Given this list of marker genes EPHA3, ANGPT4, TRIM60, CHKB, RBM24, MPPED2, SELENBP1, SUN3, CHL1, PARVA, CAMKK2, ZDHHC11, TAF10 (NCBI Gene Id 6881), SMYD2, AZIN2, CRYGD, NAV1, SFRP4, TUBA4A, CYP2S1, ROMO1, TPI1, GDF2, MYO1H, DPYSL5, EBPL, MATCAP1, NXF2, TSPYL5, SMYD1, ZNF385A (NCBI Gene Id 25946, zinc finger protein 385A), VPS28, YIF1A (Yip1 interacting factor homolog A, membrane trafficking protein), USP50, GSC2, KIAA2013, SLCO1A2, RARS2, HLA-DOA, PAM, C1R, SRP14 (NCBI Gene Id 6727), EPB41L5, CD52, SLC4A3, BRD10, LMOD2, PSPN, MIA, ADAD2, CABP5, IFI27, RYR3, MYO5B, DNAJC8, STMN2, GNAL (G protein subunit alpha L), CLDN6, SH3BGRL, TMEM139, AATK, PFKL, ABCB11, MECOM, PARVG, IQCC, C8orf58, SEC14L5, PARD3B, LHFPL4, USE1, IL25, GREM2, DACT2 (dishevelled binding antagonist of beta catenin 2), SFXN4, FOXH1 (forkhead box H1), MISP, RPS6KA3, ARHGEF11, KCNK12, NUDT18, PGC, NUDT16L1, LIAT1, SPATS2, HOXD10, METTL18, TGM2 (NCBI Gene Id 7052), CYP26B1, SQLE, USP40, LIN7A, SCN8A, PLSCR4, ORC1, JAM2, USP43, ACAT1, SCCPDH, SPATA25, NKPD1, IMPA1, EPB41L4B, SOD3, MET, DCST2, GABRA6, PPM1J (protein phosphatase, Mg2+/Mn2+ dependent 1J), MGMT, AKAP11, FHL3, CERS3, CCR9, ABCG8, MPP1, MTMR9, TEX12, ZMIZ1, PTPN14, PKDCC, SERPINE2, SLC43A2, GSC, MSRB2, DNAJB4, NTNG1, IVD, KRT2, DGUOK, NXNL2, PNMA3, PPP1R3B, GRB14, HOXC6, AHRR, ABHD14A, EMX1, ETFRF1, PDIA2, PECR, ARHGEF17 (Rho guanine nucleotide exchange factor 17), PNLIP, TET1, BTBD8, DYNC2I1, FKTN, APOC1, CYFIP1, ABCC6, LHX4, LCAT, SCML2, TM7SF3, FAM171A2, DYNLRB2, KRTAP8-1, NEO1, GAD1 (NCBI Gene Id 50977), MIGA2, AK4, BCL6B, HBB, POMGNT2, ZNF184, CLDN14, GCC2, SLC19A2, MAPK15, SIX4, NAALAD2, FAM98C, USB1, JRK, GRIA2, KCNC2, CSF2, OAZ1, SOX8, ADAM19, TBC1D8B, MAPK4, NHLRC2, CCL1, ATP2C2, SV2A, RGMA, LPP, SLC26A4, HYAL3, TMEM230, CEP43, CDCA5, ADAM33, BAAT, GUCY1B1, CCDC110, GPR20, SH3BGRL2, ALDOC, CLCN1, here is a description of the gene set: Genes down-regulated in macrophages with MYD88 knockout after M. bovis BCG infection: 24h versus 48h. studied in species Homo sapiens Human Gene Set: GSE22935_24H_VS_48H_MBOVIS_BCG_STIM_MYD88_KO_MACROPHAGE_DN from publication Qualls JE, Neale G, Smith AM, Koo MS, DeFreitas AA, Zhang H, Kaplan G, Watowich SS, Murray PJ (PMID 20716764) Nitric oxide (NO) produced by macrophages (MØs) is toxic to both host tissues and invading pathogens and its regulation is therefore essential to suppress host cytotoxicity. MØ arginase 1 (Arg1) inhibits NO production by competing with NO synthases for arginine, the common substrate of NO synthases and arginases. Two signal transduction pathways control Arg1 expression in MØs. First, a MyD88-dependent pathway induces Arg1 in intracellular infections, while a second Stat6-dependent pathway is required for Arg1 expression in alternativelyactivated MØs. We found that mycobacteria-infected MØs produce soluble factors that induce Arg1 in an autocrine-paracrine manner via Stat3. We identify these factors as IL-6, IL-10 and GCSF. We further establish that Arg1 expression is controlled by the MyD88-dependent production of IL-6, IL-10 and G-CSF rather than cell intrinsic MyD88 signaling to Arg1. Our data reveal the MyD88-dependent pathway of Arg1induction following BCG infection requires Stat3 activation and may result in the development of an immunosuppressive niche in granulomas due to the induced Arg1 production in surrounding uninfected MØs